The following is a description of a gene set: species: Homo sapiens Activation of kainate receptors upon glutamate binding Human Gene Set: REACTOME_ACTIVATION_OF_KAINATE_RECEPTORS_UPON_GLUTAMATE_BINDING, and this is the list of marker genes: CALM1, GNGT1, GNG12, GRIK5, GNB1, GNG10, GNB2, GNB5, GRIK3, GNB3, GNG5, GNG11, NCALD, DLG4, GRIK2 (glutamate ionotropic receptor kainate type subunit 2), GNG8, GNG7, PLCB2, GRIK4, GNG13, GNB4, DLG1, GNG2, GNG4, PLCB3, GNG3, GNGT2, GRIK1, PLCB1, DLG3